Given this list of marker genes CCNG2, MCM5, CCND2, POLE2 (NCBI Gene Id 5427), WEE1, ORC5, CREB3L3, ORC6, CDK6, CCNE1, ORC1, CCNA1, CCNE2, CDKN2A, RPA3, E2F2, CDKN1A, TFDP2, PCNA, CDKN2C, CREB1, MYC, ORC3, MNAT1, CDC25A (cell division cycle 25A), RPA1 (NCBI Gene Id 6117), MDM2 (MDM2 proto-oncogene), E2F1, RB1, POLE, MCM2, CCNH, MCM4, CDC45, CREB3L1, CREB3L4, CDKN2D, CCND1, RPA2, CDK2, PRIM1, ATM, ORC4, CDKN1B, MCM3, MCM6 (minichromosome maintenance complex component 6), CDKN2B, MYT1, CREB3, POLA2, CDK7 (cyclin dependent kinase 7), TP53, ATF6B, CDKN1C, MCM7, TFDP1, GADD45A, CCND3, CDK1, E2F3, ORC2, CCNB1, PRIM2, CDK4, here is a description of the gene set: species: Homo sapiens G1 to S cell cycle control Human Gene Set: WP_G1_TO_S_CELL_CYCLE_CONTROL